Given this list of marker genes MED14, PCK1, NCOA6, MED30, TGFB1, RXRA, LEP, WNT1, MED25, HDAC3, PLIN1, CDK19, CDK8, ZNF638, MED11, MED13L, MED20, MED21, TBL1XR1, CCNC, SLC2A4, MED24, CEBPA, MED13, NFKB1, PPARG, ADIPOQ, NCOR1, MED31, RELA, MED1, MED19, CEBPB, KLF5, MED16, THRAP3, NCOA3, CDK4, ADIRF, KLF4, CREBBP, EBF1, EP300, MED9 (NCBI Gene Id 55090), MED7, WNT10B, FABP4, PPARA, CCND3, ZNF467, MED15, CD36, MED27, CEBPD, MED12, MED17, NCOR2, TGS1, CARM1, SMARCD3, NCOA1, MED28, FAM120B, MED4, NCOA2, MED23, MED8, MED22, HELZ2, MED6, PPARGC1A, MED10, CHD9, NR2F2, LPL, MED29 (NCBI Gene Id 55588), TNF, ANGPTL4, MED18, MED26, SREBF1, TBL1X, EGR2, SREBF2, here is a description of the gene set: Human Gene Set: REACTOME_TRANSCRIPTIONAL_REGULATION_OF_WHITE_ADIPOCYTE_DIFFERENTIATION Transcriptional regulation of white adipocyte differentiation species: Homo sapiens